The following is a description of a gene set: species: Homo sapiens The chemical reactions and pathways involving tetrahydrofolate, 5,6,7,8-tetrahydrofolic acid, a folate derivative bearing additional hydrogens on the pterin group. Human Gene Set: GOBP_TETRAHYDROFOLATE_METABOLIC_PROCESS, and this is the list of marker genes: MTHFD2, DHFRP1, AASDHPPT, SLC46A1, DHFR2, ALDH1L1, MTHFD2L, GCH1, MTHFD1, MTR, SHMT1, FOLR1, ATIC, MTHFD1L (NCBI Gene Id 80244), MTHFR, ALDH1L2, TYMS, DHFR, SHMT2, MTHFS